Given this list of marker genes DNAJC15, MIR210, CHCHD2 (NCBI Gene Id 92547), CCNB1, CDK1, GHITM, SNCA, here is a description of the gene set: Human Gene Set: GOBP_REGULATION_OF_MITOCHONDRIAL_ATP_SYNTHESIS_COUPLED_ELECTRON_TRANSPORT species: Homo sapiens Any process that modulates the frequency, rate or extent of mitochondrial ATP synthesis coupled electron transport.